The following is a description of a gene set: Reduction of goal-directed behaviors linked to the impairment in frontal executive functions (planning of an action for example). Inertia species: Homo sapiens Human Gene Set: HP_INERTIA, and this is the list of marker genes: JPH3, PANK2, FMR1, ATXN1, PRKAR1B